The following is a description of a gene set: The process of synaptic transmission from a neuron to another neuron across a synapse. studied in species Mus musculus Mouse Gene Set: GOBP_NEURON_NEURON_SYNAPTIC_TRANSMISSION, and this is the list of marker genes: Cacna1a, Pnoc, Drd2, Kif1b, Oprl1, Vdac1, Pten, Camk4, Tmod2, Arid1b (NCBI Gene Id 78879), Vdac3